Given this list of marker genes Ptprc, Cd72, Sema4d, Tyrobp, Plxnd1, Trem2, here is a description of the gene set: This event has been computationally inferred from an event that has been demonstrated in another species.<p>The inference is based on the homology mapping from PANTHER. Briefly, reactions for which all involved PhysicalEntities (in input, output and catalyst) have a mapped orthologue/paralogue (for complexes at least 75% of components must have a mapping) are inferred to the other species. studied in species Mus musculus electronically inferred by orthology from the curated human pathway Reactome Pathway: Other semaphorin interactions part of: Semaphorin interactions